The following is a description of a gene set: Trans-sulfuration, one-carbon metabolism and related pathways Human Gene Set: WP_TRANSSULFURATION_ONECARBON_METABOLISM_AND_RELATED_PATHWAYS studied in species Homo sapiens, and this is the list of marker genes: MAT2B, DMGDH, SARDH, CDO1, TYMS, AHCYL2, BCAT2, SOD3, GCLM (glutamate-cysteine ligase modifier subunit), GPX4, AHCY, SOD2, AMT, GCLC, CTH (NCBI Gene Id 63046), GAD2, GPX3, PSAT1, BAAT, PCYT1B, PEMT, PHGDH, CHDH, CBS, GSR (glutathione-disulfide reductase), DNMT3A, SHMT1, ETNK1, GPX7, BHMT, GPX6, MTHFD2, MAT1A, SLC25A48, GNMT, GSS, CHKB, MTHFD2L, DHFR2, DHFR, GAD1, BCAT1, MTR, PLD1, CHPT1, MTHFR, ETNK2, ENSG00000274276, MTHFD1, PCYT2 (phosphate cytidylyltransferase 2, ethanolamine), SHMT2, CEPT1, GPX2, AGXT2, PCYT1A, GPX1, DNM1, MTHFD1L, DNMT3B, MAT2A, PSPH, GPX5, CSAD, BHMT2 (betaine--homocysteine S-methyltransferase 2), SOD1, ALDH7A1 (aldehyde dehydrogenase 7 family member A1), CHKA, DNMT3L, AHCYL1 (NCBI Gene Id 29039)